The following is a description of a gene set: from publication Chen Y, Wang X (PMID 31504780) Mouse Gene Set: MIR_3087_3P Genes predicted to be targets of miRBase v22 microRNA mmu_miR_3087_3p in miRDB v6.0 with MirTarget v4 prediction scores > 80 (high confidence targets). species: Mus musculus, and this is the list of marker genes: Aak1, Atxn7l3, Cer1, 9530068E07Rik, Hars2 (NCBI Gene Id 70791), Gucy1a2, Fbxo22, B230219D22Rik, Slit3, Brd3, Map1b, Fbxo5 (F-box protein 5), Pkdcc, Eml5, Fgd5, Cd226, Brox, Neto2, Tpd52, Dph2, Zic4, Ubxn7, Mapk6, Hoxd9, Desi1, Snapc1, Fbxl17, Ppp2r5e, Nos3, Slc17a2, Med13l, Tbr1 (NCBI Gene Id 21375), Dazl, Scai, Smarcad1, Hdac2, Adamts5, Fam199x, Cwf19l2, Ptpn14 (NCBI Gene Id 226829), Sema6d, Edil3, Myef2, Aldh9a1, Scd1, Nfasc, Slc25a14, Sntg1, Fndc3a, Tspan6, Rprd1a, Nfat5, Cep70, Srrm2, Clec2g, Prpsap2, Plagl1, Tnfsf13b, Wnt3, Phaf1, Stox2, Scrn3, Kansl2, Pnpla8, Prkd3, Bnip3l, Vxn, Zpld1, Trp53inp1, Polr3k, Slitrk4, Nedd9, Lypla1, Myot, Ctbp2 (NCBI Gene Id 52060), Foxi1, Ilf3, Larp4, Tcf12, Fyn, Tox3, Capn9, Slc9a1, Ddx51 (NCBI Gene Id 97281), Hnrnpf, Rimoc1, Prss44, Paxbp1, Pex13